Given this list of marker genes ARF5, GMFB, GALNT1, KHDRBS1, SCG5, YBX1, RPA2, ADAM9, BMP1 (bone morphogenetic protein 1), MMP2, DUSP14, MMP1, RPA1, AOX1, MMP7, HMGB1, TF, MMP3, ZNF117, MMP14, ARF4, MMP9, SSBP1, HSPB2, MMP10, UBA2, here is a description of the gene set: Human Gene Set: MODULE_371 Genes in the cancer module 371. species: Homo sapiens